The following is a description of a gene set: species: Mus musculus The process whose specific outcome is the progression of the cranial nerves over time, from its formation to the mature structure. The cranial nerves are composed of twelve pairs of nerves that emanate from the nervous tissue of the hindbrain. These nerves are sensory, motor, or mixed in nature, and provide the motor and general sensory innervation of the head, neck and viscera. They mediate vision, hearing, olfaction and taste and carry the parasympathetic innervation of the autonomic ganglia that control visceral functions. Mouse Gene Set: GOBP_CRANIAL_NERVE_DEVELOPMENT, and this is the list of marker genes: Six4, Tfap2a, Adarb1, Gli3, Slc24a4, Slitrk6, Ext1 (NCBI Gene Id 14042), Nrp2, Sall1, Slc1a3, Slc25a46, Egr2, Plxna3, Chd7, Tcirg1, Hoxb3, Phox2b, Hoxb2, Chrnb2, Hoxd3, Tbx1, Hes3, Atoh7, Hoxa1, Ephb1, Pou4f1, Phox2a, Hes1, Ntrk1, Tmem126a, Nrp1, Isl1, Atp8b1, Ackr3, Six1, Ephb2, Kcna3 (NCBI Gene Id 269476), Drgx, Tifab, Rpl24, Hoxa3, Npr2, Kcna1 (NCBI Gene Id 17205), Hoxb1, Dmd, Nkx2-2, Erbb3, Ndp, Plxna1, Slc38a8, Kcnc1, Nav2, Sema3f, Ctnnb1, Plxna4, Neurog1, Kcna2, Mafb, Pou4f3, Pax2, Kcnc2, Sema3a, Cited2, Lpar1